The following is a description of a gene set: Genes predicted to be targets of miRBase v22 microRNA hsa-miR-296-5p in miRDB v6.0 with MirTarget v4 prediction scores > 80 (high confidence targets). from publication Chen Y, Wang X (PMID 31504780) Human Gene Set: MIR296_5P studied in species Homo sapiens, and this is the list of marker genes: DPYSL5, CRYGS, DYNLL2, CHCHD4 (NCBI Gene Id 152281), CELSR3, ST3GAL3, NACC2, PLK1, CBX6, LYPLA2, SPHKAP, SUN2 (Sad1 and UNC84 domain containing 2), HIPK1, BOK, COMMD7, FCHSD1, HMGA1, USP12, NFIC, PLPPR5, GRK6 (G protein-coupled receptor kinase 6), CHMP1A, CCAR2, KCTD15, ACTR1A (actin related protein 1A), FAM78B, SLC38A3, ZNF512B (NCBI Gene Id 57473), KLK2, DDR1, P2RX6, ZNF334, F11R, SNAI1 (snail family transcriptional repressor 1), UBAP2L, GSDMD, ADAMTS10, MST1R, AMMECR1L, SLC25A35, NUMBL, GIGYF1, GDF10, DYRK1B, ANGEL1, XG, KCNQ2, CMTM4, UNC5A, UBAP1, CPLX3, SRRM4, ZMYM3, MYH14